The following is a description of a gene set: Cytokines mediate cell-cell communication in the immune system and represent important therapeutic targets. A myriad of studies have highlighted their central role in immune function, yet we lack a global view of the cellular responses of each immune cell type to each cytokine. To address this gap, the authors created the Immune Dictionary, a compendium of single-cell transcriptomic profiles of more than 17 immune cell types in response to each of 86 cytokines (>1,400 cytokine-cell type combinations) in mouse lymph nodes in vivo. A cytokine-centric view of the dictionary revealed that most cytokines induce highly cell-type-specific responses. For example, the inflammatory cytokine interleukin-1β induces distinct gene programmes in almost every cell type. A cell-type-centric view of the dictionary identified more than 66 cytokine-driven cellular polarization states across immune cell types, including previously uncharacterized states such as an interleukin-18-induced polyfunctional natural killer cell state. Mouse Gene Set: CUI_CDC1_IFNB_RESPONSE_DN studied in species Mus musculus from publication Cui A, Huang T, Li S, Ma A, Pérez JL, Sander C, Keskin DB, Wu CJ, Fraenkel E, Hacohen N (PMID 38057668) Genes negatively differentially expressed in cell type: cDC1 (conventional dendritic cell type 1) upon treatment with cytokine: IFN-β in mouse lymph nodes in vivo., and this is the list of marker genes: Eif3g, Tsc22d4, Man1a2, Asap1, Klf2, Bmp2k, Hexa, Mri1, Rnd3, Emp3, Sf3b1, Pld4, Slc4a7, Hp1bp3, Myo1f, Ivns1abp, Klf4, Kmt2c, Calm2, Eif3k, Hepacam2, Cenpv, Tnrc6b, Ddx27, Slc66a2, Lipa, Xpr1, Gnl3, Eif4a2, Ddx6 (DEAD-box helicase 6), Mapk14, Mxd4, Ypel3, Pabpc1, Naca, Glul, Eid1, Itm2c, Chd4, Rgs10, Nsa2, Rtl8b, Hnrnpl, Inpp5d, Phf14, Atf6b, Npm1, Foxp1, H2az1, Smc4, Tyrobp, Rnf150, Cd300c2, Set, Aimp1, Uqcr10, Ighm, Ccr5, Fam168b, Eif3a, Ier2, Fcgrt, Dad1, Lmo4, Pak1, Macf1, Cnbp (cellular nucleic acid binding protein), Nedd4, Tm6sf1, Fxyd5, Arap1, Creg1, Zmynd8, Alox5ap, Colgalt1, Camk1d, Septin3, Grk2, Samd1, Rgs2, Csnk1g2, Srebf2, Mybbp1a, P4hb, Ptpn11, Rassf4, Usf2, Ccr2, Parp1, Hnrnpu, Uba52, Hnrnpa0, Mlec, Tubb2a, Erp29, Kcnq1ot1, Atp6v0b, Mbd3, D8Ertd738e, Ramp1, Polr2h, Cat, Impa2, Fermt3, Echs1, Abcc1, Llph, Fosb, Imp3, Lyz2, Trp53, Bin1, Ppp1r14b, Irag2, Jun, Polr2e, Nr4a2, Proser2, Eif5, Nop58, Snapc5, Ap1b1, Arhgap45, Tm2d2, Eea1, Trf (transferrin), St8sia4, St3gal5, Tbc1d9, Cox7a2l, Gdi2 (GDP dissociation inhibitor 2), Srsf11, Polr2j, Zfp398, Pold4, Eif3b, Fth1, Kit, Clec12a, Atrx, Zfp36l2, Klhl24, Eprs1, Tlr12, Acss1, Fcgr2b, Lamtor4, Xist, Eef1d, Ssr1, Myo18a, Nostrin (NCBI Gene Id 329416), Tnpo1, Aph1c, Pianp, Laptm5, Cd44 (CD44 antigen), Rad50, Gpx1, Tmco1, P3h2, Sf3a1, Ap2a2, Tnfaip8, Cdk4, Cd81, Top2b, Tle5, Serbp1, Tubb5, Arhgap18 (NCBI Gene Id 73910), Paip2, Eif3l (NCBI Gene Id 68333), Zmiz1, Gle1, Sec11c, Fos, Siglecg, Eif4ebp2, Rtcb, Itgb2, Hdgf, Ran, Galc, Gpsm3, Plbd1, Upf3b, Anp32b, Rtl8a, Scd2, Ciita, Bcas2 (BCAS2 pre-mRNA processing factor), Vsir, Srgap3, Rsl1d1, Fnbp1, Cebpz, Was, Top1, Mast4, Eif4g1, Ncl, Pdcd4, Ubash3b, Eef1g, Lrrk2, Ifngr1, Mrpl52, Rp9, Tomm5 (translocase of outer mitochondrial membrane 5), Nup210, Glrx5 (NCBI Gene Id 73046), Hmgb1, Abce1, Eif3e, Kctd12, Znrf2, Exosc5, Ddx10, Dusp1, Ucp2, Ctsh, Syne1, Orai2, Ddx46, Nap1l1